Given this list of marker genes RABGAP1L, ZNF566, ZNF655, HIPK1, RMND5A, SLC25A29, TAF5, TOMM70, PHYHIPL, CRYBG3, PRKRA, ANKRD17, KANK2 (KN motif and ankyrin repeat domains 2), SCARB2, UBE2N, BEX2, EPM2AIP1, SPAG9, MEX3C, DMTF1, SPAST, EPC2, BSDC1, USP37 (NCBI Gene Id 57695), VEZF1, NCAM1, CHTOP, KMT2E, RALGAPA1, ZFP14, EIF4ENIF1, USP19, ZHX1, CEP170, FOXO3, PPM1B, RBM4B, ARID4B, FAM8A1 (family with sequence similarity 8 member A1), PDCL, ZNF462, BTRC, CEP76 (centrosomal protein 76), NFYA, HECTD3, KPNA3, CRNKL1, TARDBP, NCOA5, CCDC82, KAT6B, MARCHF6, FANCL, ISOC1, HNRNPH3, FBXO3, NGRN, KLHL42, SMC3, PTBP2, CDC5L, USP33, LUC7L3, PATZ1, CLK4, RIOX2, KAT7, KIDINS220, CAND1, SLC5A3, ZMYM2, RABGEF1, SS18L1, NLK, NUDT4, QSER1, NAA30, RBM25, ELP1, PHF2, CREBRF, HMG20A, MED17, DFFA, PPM1E, GSK3B, ZFAND5, ACSL3, CELF1, LEMD3, HEATR5B, SYNC, DYNC1I2, HNRNPU, SMAD2, CNOT7, EXOC5, UBE2E3, GNE, TRAPPC6B, ZNF529, PAIP1, NAA25 (NCBI Gene Id 80018), PARP6, NPTX1, PAFAH1B2, ISCA1, TUBGCP3, UBE2H, NAB1 (NCBI Gene Id 4664), ARID1A, BRPF3, FBXO30, REPS1, DHX36, KMT5B, C2CD3, here is a description of the gene set: Neighborhood of ZNF198 NULL in the GCM expression compendium studied in species Homo sapiens Neighborhood of ZNF198 Human Gene Set: GCM_ZNF198